Given this list of marker genes DCLRE1C, LINC00472, FOSL1, MAGI1, ZBTB43, BCL10, RAB4B, CCNP, ATF3, FCAR, PTPN12, MYO1C, YBX3, ZNF467, RIGI, NR1H2, PPP2R1A, PPFIA3, PFKFB3, CRISP1, BAZ1A, KCTD5, TMEM8B, CPNE3, DENND3, CLMN, IFT56, FAM131A, LRRFIP1, TM9SF1, ATP6V1B1, KLF2, MAU2, SLN, NUMB, IL10, MSL1, TMEM158 (transmembrane protein 158), NPVF, PACSIN2, ZNF292, NECTIN2, KRT23, ANAPC13, ADIPOR1, PHACTR1, LIMK2, ALPK1, CANT1, SGK2, E2F4, SPON1, FTH1, GBP2 (guanylate binding protein 2), AGPAT2, BCL6, HOXC11, CYP11B1, MAP2K3, CCN2, OR10J1, PRKAR2A, CHD1, SPAG9, TMEM33, DNAI1, AGO4, MCF2L, PTGES, PRR34, SIPA1L1, HAUS2, PGLS, XKR8, SPRY4, SLC12A6, S100A12, MCL1, ATP1B2, NFS1, ENSG00000290731, CPPED1 (calcineurin like phosphoesterase domain containing 1), CDA, ACOX1, DAPP1 (NCBI Gene Id 27071), RUBCNL, ITIH5, SCML1 (NCBI Gene Id 6322), PFN2, CSAD, GLB1L2, UBXN7, MYO5A, CHST12, NUP58, TTPAL, EHD1, GARRE1, MAK, C1orf216, PRRG1, ART1, SLCO3A1, DUSP2, ACTN1, CAMK2B, LPGAT1, NRBF2, PRRG4, CHD4, LONRF3, POLB, INE1, DNAJA4, SLC22A4, CFLAR, LPP, CEACAM4, CDC42EP2, LTB, RHBDF2, DNAJC3, SMIM27, ZNF446, RPS6KB2, HAUS4, SECTM1, ADGRV1, NDRG2, GMIP, COA7, P4HA2, CHAD, MOCS3, ERF, PPP1CB, CYTH4, ACP3, GFOD2, FMO6P, CYBA, CD320, YIPF6, PGGHG, SLC22A14, CAND2, TREML2, TUBA8, INSL4, GOLGB1, CACNA1H, SEMA4A, LARP4B, PHLDA1, C6orf62, HTR2A, SLC20A1, GTPBP1, RET, HOOK2, ANXA3, SEMA3G, LSM12, HAUS5, SERPINC1, PCDH12, OR10H1 (NCBI Gene Id 26539), FGR, DHODH, KLHL11 (kelch like family member 11), HSD3B1, PVALB, DHX40, SCAF11, ZNF473, PLEKHJ1, VPS37A, TCIRG1, MGLL, IPCEF1, NEU3, KCNJ8, TAS2R13, STARD13, IMPDH1, RHOA, AGFG1, LILRA3, RELB, MLPH (NCBI Gene Id 79599), TNNC2, IMPA2, SLC4A4, PRRC2A, KAT7, SH2D3C, HIGD1B, here is a description of the gene set: species: Homo sapiens Human Gene Set: GSE3982_NEUTROPHIL_VS_BASOPHIL_UP from publication Jeffrey KL, Brummer T, Rolph MS, Liu SM, Callejas NA, Grumont RJ, Gillieron C, Mackay F, Grey S, Camps M, Rommel C, Gerondakis SD, Mackay CR (PMID 16474395) In the present study we used Affymetrix oligonucleotide microarrays to produce gene transcription profiles for the major leukocyte types in humans. This comprehensive dataset enabled us to not only establish which genes were expressed in each leukocyte type, but also which genes were expressed in each subset after activation. The used of a comprehensive dataset of gene profiles from all the major human leukocyte subsets enabled a novel and powerful means for identification of genes associated with single leukocyte subsets, or different immune paradigms. Genes up-regulated in comparison of neutrophils versus basophils.